The following is a description of a gene set: In the kidney water and solutes are passed out of the bloodstream and into the proximal tubule via the slit-like structure formed by nephrin in the glomerulus. Water is reabsorbed from the filtrate during its transit through the proximal tubule, the descending loop of Henle, the distal convoluted tubule, and the collecting duct.<br>Aquaporin-1 (AQP1) in the proximal tubule and the descending thin limb of Henle is responsible for about 90% of reabsorption (as estimated from mouse knockouts of AQP1). AQP1 is located on both the apical and basolateral surface of epithelial cells and thus transports water through the epithelium and back into the bloodstream.<br>In the collecting duct epithelial cells have AQP2 on their apical surface and AQP3 and AQP4 on their basolateral surface to transport water across the epithelium. The permeability of the epithelium is regulated by vasopressin, which activates the phosphorylation and subsequent translocation of AQP2 from intracellular vesicles to the plasma membrane. Reactome Pathway: Vasopressin regulates renal water homeostasis via Aquaporins part of: Aquaporin-mediated transport studied in species Homo sapiens, and this is the list of marker genes: GNG12, AQP2, PRKACB, ADCY6, GNG4, ADCY1, MYO5B, PRKAR1B, AQP1 (NCBI Gene Id 358), RAB11FIP2, GNG3, RAB11A, GNG10, GNG8, PRKAR2A, GNAS, GNG7, AQP4 (aquaporin 4), PRKAR1A, PRKAR2B, ADCY4, ADCY2, GNG11, GNB5, AQP3, PRKACG, ADCY3, GNG2 (NCBI Gene Id 54331), PRKACA, AVPR2, ADCY9, AVP, GNB4, ADCY7, ADCY8, GNGT2, GNB1, GNB3, ADCY5, GNB2, GNGT1, GNG5, GNG13